Given this list of marker genes Slc6a3, Slc22a2, Stx1a, Slc6a2, Plcd1, Agt, Hrh3, Adora3, Oxtr, Ptgs1, Agtr2, Adora2b, Slc18a1 (solute carrier family 18 (vesicular monoamine), member 1), Slc29a4 (solute carrier family 29 (nucleoside transporters), member 4), Nisch, Slc22a3, Adora2a, Crhr2, Oxt, Kcnb1, Snca (synuclein, alpha), Ghsr, Slc29a3, P2ry1, Ffar3, Slc22a1, Crh, Actb, Comt, P2ry12, Chrna7, Ptger3, here is a description of the gene set: Mouse Gene Set: GOBP_NOREPINEPHRINE_TRANSPORT The directed movement of norepinephrine into, out of or within a cell, or between cells, by means of some agent such as a transporter or pore. Norepinephrine (3,4-dihydroxyphenyl-2-aminoethanol) is a hormone secreted by the adrenal medulla and a neurotransmitter in the sympathetic peripheral nervous system and in some tracts of the CNS. It is also the biosynthetic precursor of epinephrine. studied in species Mus musculus